The following is a description of a gene set: Any process that stops, prevents or reduces the frequency, rate or extent of AIM2 inflammasome complex assembly. Mouse Gene Set: GOBP_NEGATIVE_REGULATION_OF_AIM2_INFLAMMASOME_COMPLEX_ASSEMBLY studied in species Mus musculus, and this is the list of marker genes: Mndal, Ifi209, Ifi203-ps, Ifi214, Ifi208, Ifi213, Ifi206, Ifi203, Ifi207, Trim11